Given this list of marker genes Ehmt1, Hopx, Alg6, Cbx8, Zfp60, Phf8, Kcnj2, Trappc6b, Cdh5, Naa30, Epm2aip1, Cngb1, Tti2, Osbpl8, Pigp, Susd6, Zfp148, Ube2s, Strap, Gucy1a2, Hs3st3a1, Rnf113a2, Smc3, Pak1, Ehd4, Fbxo4, Slco2b1, Tra2b, Smarca1, B020004C17Rik, Dgkb, Actr2, Kera, Tacc2, Ppfibp1, Mogs, Serpinb11, Mdh1, Napepld, Stag2, Glcci1, Cxadr, Hand1 (heart and neural crest derivatives expressed 1), Nhs, Mmd, Ythdc2, Cpne8, Sypl1, Sim1, Cdkl4, Ankra2, Lrrtm2, Noxo1, Samt1c, Vwc2, Tmem263, Slc7a11, Tspan13, Vta1, Csn1s1 (NCBI Gene Id 12990), Nup62, Mpp4, Sox6, Kitl, Foxa2, Ccdc85a, Gpr21, Cd9, Slc25a22, Zfp809, Pla2g5 (phospholipase A2, group V), Fgd4, Cfap20 (cilia and flagella associated protein 20), Gm16445, Pank3, Rsf1, Rev3l, Osbpl1a, Gabra4, Ugt2a3, Myo19, Pex13, Ubl3, Esp34, Naaladl2 (NCBI Gene Id 72682), Ltn1, Wdfy3, Tmtc3, Ptbp3, Snx13, Pfkfb2 (NCBI Gene Id 75925), Depdc7, Secisbp2l, Pwwp3b, Nhlh2, Morn1, Pla2g3, Entr1, Gria4, Thoc2 (NCBI Gene Id 434773), Cntn3, Acadsb, Cox16 (cytochrome c oxidase assembly protein 16), Acbd5, Sqor, Septin10, Lrrtm4, Oat, D17H6S53E, Tjp1, Actl6a, Pof1b, Zfp747, Stc2, Kcnab1, Cyp20a1, Eny2, Kpna3, Zfp248, Hspa4, Foxb1, Yipf3 (NCBI Gene Id 28064), Lhcgr, Mat2b, Tiprl, Cpeb2, Krtap15-1, Ap3s1, Nudt4, Parp8, Esp31, Baz2a, Trib2, Dmrta1, Gpr85, Tex12, Rnls, Cyp2j6, Avl9, L2hgdh, Batf, N4bp1 (NCBI Gene Id 97462), Efhc1, Krt6a, Msl3 (NCBI Gene Id 17692), Nup205, Zfpm2, Srrm1, Gosr1, Hnrnpr, Tspan14, Corin, Ms4a2, Zdbf2, Prkcd, Tcf12, Samd8, Socs6 (NCBI Gene Id 77635), Fam76b, Exph5, Mlx, Card19, Mmp24, Capn3, Gabrg1, Ranbp3l, Boc, Lrrc57, Btbd1, Gucy1a1, Ube2w, Trub1, Dpyd, Unc93a, Ccdc87, Mark3, Rbfox1, Fnip1, Lca5, Rfx3, Irf2, Crebrf, Lyn, Alg14, Arrdc3, Tecrl, Celf3, Syde2, Ptk2, Esp18, Lin9, Treml1, Oaz1, Sbno1, Txndc5, Snrpg, Aplf, Il1rap, Cyp4a31, Ints5, Wnt5b, Pcdh9, Samt1d, Adam28, Fam185a, Samt1, Scn1a, Psmd11, Irf6, 1110004F10Rik, Mpp7, S2bpcox16, Adhfe1, Armcx5, Ptprk, Gmcl1, Sec11c, Gabra6, Mtdh, Fbxl17 (NCBI Gene Id 76180), Dip2a, Klhl12, Chic1, Nt5e, Lin28b, Gm10778, Mcm8, Zmiz1, Rab14, Phf3, Itgb3bp, Ccdc88a, Efcab14, Sgpp1, Trim30b, Jam3, Casp8, Kndc1, Samt1b, Tle4, Zfp738, Zfp729b, Gins3, here is a description of the gene set: Mouse Gene Set: MIR_465D_5P Genes predicted to be targets of miRBase v22 microRNA mmu_miR_465d_5p in miRDB v6.0 with MirTarget v4 prediction scores > 80 (high confidence targets). studied in species Mus musculus from publication Chen Y, Wang X (PMID 31504780)